The following is a description of a gene set: We demonstrated recently that both constitutive and FAS-triggered apoptosis of human neutrophils are profoundly impaired by Francisella tularensis, but how this is achieved is largely unknown. To test the hypothesis that changes in neutrophil gene expression contribute to this phenotype, we used human oligonucleotide microarrays to identify differentially regulated genes in cells infected with F. tularensis strain LVS compared with uninfected controls. In order to examine the effect of F. tularensis on the neutrophil transcriptome, we performed microarray expression analysis on human neutrophils treated with F. tularensis subsp. holarctica live vaccine strain (LVS). from publication Schwartz JT, Bandyopadhyay S, Kobayashi SD, McCracken J, Whitney AR, Deleo FR, Allen LA (PMID 22986450) species: Homo sapiens Genes down-regulated in comparison of control polymorphonuclear leukocytes (PMN) at 0 h versus PMN treated with F. tularensis vaccine at 6 h. Human Gene Set: GSE37416_0H_VS_6H_F_TULARENSIS_LVS_NEUTROPHIL_DN, and this is the list of marker genes: GPR84, NFKBIA, FBXO34, MIR23AHG, RAB5C, EDEM1, IDH2, MAPK6 (NCBI Gene Id 5597), TOP2B, CXCL16 (C-X-C motif chemokine ligand 16), CYB5D1, KCNH2, AGO2, NANOS3, GZF1, HPS5, ATP1A1, KDM3A, FBRSL1, ETV3, ENO1 (enolase 1), DOCK4, ERMN, ARMCX3, CYLD, NOTCH4, CHMP4A (NCBI Gene Id 338010), BRAF, SNAPC1, MIR9-1HG, TNF, DYNLT3, RASSF7, PKM, PDE4B, FBN1, TFRC, BCL2A1, PDK1, C12orf42, RHCE, FUT11, TGIF2, OXSM, GPATCH2L, NUP58, PRKAG2-AS2, RASSF5, IL10RA, LATS2, SLC36A4, PDLIM7, GUK1, PHF20, CREB3, TOM1, SLC2A3, MEPCE, ZBTB25, MAP3K13, CHD2, CD83, SRGN, TRAK1, EIF2S3, SQSTM1, MAP2K1, KANSL3, RBPJ, GPR65, GGT1, GINS4, PIK3R5, GADD45G, NCOR2, SAMD4B, ZNF292, MADD, NFKB1, IVNS1ABP, BMP6, STX4, IPPK, SAMSN1, FNDC3B, GGTLC1, EFNA3, SPAG9, IER3, SPHK1, MAFF, OLR1, PABPC1 (NCBI Gene Id 26986), BHLHE40, CUX1, ZBTB1, ICAM1, PTP4A2, TRIM39, DNAJA2, IL4R, ZMIZ1, SNX20, SAR1B, IER5, SRA1, CRTC2, PTPN7, PLAUR, SLC16A3, FKBP2, SOD2, DENND5A, MAPKAPK2, HDHD5, GNG2, MAP2K3, SERP1 (NCBI Gene Id 27230), TMEM41B, CBX5, AZIN1, G3BP2, STAT4, EAF1, BRPF3, ELL2, SLC3A2, BANP, ADIPOR2, RLF, MED14, GNA15, CDKN1A, SIPA1L1, HMGA1, SLC43A3, PIK3IP1, HMGXB3, NINJ1, ENTPD4, RNF103, NFKBIE, NEDD9, RILPL2, TXNDC11, RUNX3, CHMP4B, AFTPH, RAB33A, CCNH, GPAT4, LAMB3, INSIG1, BORCS5, CDK17 (NCBI Gene Id 5128), ZHX2, PRR5L, TIPARP, KLF10, TENT4A, MFAP1, BID, GTPBP1, ABCF1, B3GNT5, ATXN2L, SIK2, NBEAL1, ZNF267, SNN, CERK, DIABLO (NCBI Gene Id 56616), ZNF277, SPAG4, PPCDC, PHF1, PSMA6, SLC35B2, TNFAIP6, DDX41, ATP13A3, PRKCI, FRMD4B, PPP1R14B, SERPINB9P1, OXSR1, RAB5A, STX6, DUSP2, BZW1, P4HA1, SH3D21, RIMKLA, GAPDH, ADM, BRD4, CLPTM1L, FAM162A